Given this list of marker genes STIP1, KIF20A (NCBI Gene Id 94421), CDC20, NUDT1, RACGAP1, CCNE2, MELK (NCBI Gene Id 9833), H2AZ2, MKI67, MIS18A, XPOT, E2F8, NCAPG, CDKN3, CEP55, CMC2, TIMM10, DNAJC9, ESPL1, NEK2, PTTG3P, BIRC5, CCNB2, EZH2, CKS2, ASPM, PTTG1, PSMA7, TOMM70 (NCBI Gene Id 9868), SNRPG, QPRT, DLGAP5, GMPS, BLM, PFDN6, ORMDL2, TACC3, H2AZ1, NME1, SNRPC, HCCS, SLC52A2, MCM3, DSCC1, MCM2, FOXM1, KIF14, APOBEC3B, SNRPF, MRPS17, HMCES, COX7B (NCBI Gene Id 1349), TPX2, MCM6, CDK2, PIMREG, RNASEH2A (NCBI Gene Id 10535), JPT1, HMGB3, KPNA2, ZWINT, UBE2S, UBE2N, GTPBP4, STIL, MCM4, CENPE (NCBI Gene Id 1062), TXN, E2F1, KIF18B, TIMELESS, CDCA8, CENPI, CENPF, KIF11, PKMYT1, TXNRD1, CENPN, RAD54B, CDC45, KIF2C, SPAG5, TOP2A, FBXO5, RFC4, LAGE3, UBE2C, CENPA, CCNA2, NCAPG2, NCAPH, PDSS1, RAB5IF (RAB5 interacting factor), RRM2, TUBA1B, DONSON, NUSAP1, JMJD6, AURKA, CDC25A, TMPO, POLR2K, PSMD12, MCM10, PLK1, CDK1, TROAP, ECT2, NDC80, VRK1, BUB1, TRIP13, BYSL, NUTF2, GTSE1, GINS1, CENPU, CCNB1, MRPL12, CCT5, TUBA1C, PRC1, TTK, DDX39A, HMMR, CDCA3, MRPL15, RAD51, EXO1, TUBA1A, BOLA2, BUB1B, HJURP, KIF15, AURKB, FEN1, MYBL2, SHMT2, CHEK1, ITCH, MARS1 (NCBI Gene Id 4141), ELOC (elongin C), SLC7A5, H4C2, DSN1, KIF4A, OIP5, PARPBP, NUP93, MAD2L1, STMN1, POLQ, LMNB1, KIFC1, here is a description of the gene set: Up-regulated genes whose expression correlated with histologic grade of invasive breast cancer tumors: comparison of grade 1 vs grade 3. studied in species Homo sapiens Human Gene Set: SOTIRIOU_BREAST_CANCER_GRADE_1_VS_3_UP BACKGROUND: Histologic grade in breast cancer provides clinically important prognostic information. However, 30%-60% of tumors are classified as histologic grade 2. This grade is associated with an intermediate risk of recurrence and is thus not informative for clinical decision making. We examined whether histologic grade was associated with gene expression profiles of breast cancers and whether such profiles could be used to improve histologic grading. METHODS: We analyzed microarray data from 189 invasive breast carcinomas and from three published gene expression datasets from breast carcinomas. We identified differentially expressed genes in a training set of 64 estrogen receptor (ER)-positive tumor samples by comparing expression profiles between histologic grade 3 tumors and histologic grade 1 tumors and used the expression of these genes to define the gene expression grade index. Data from 597 independent tumors were used to evaluate the association between relapse-free survival and the gene expression grade index in a Kaplan-Meier analysis. All statistical tests were two-sided. RESULTS: We identified genes in our training set that were associated with histologic grade; most of these genes were involved in cell cycle regulation and proliferation. In validation datasets, the gene expression grade index was strongly associated with histologic grade 1 and 3 status; however, among histologic grade 2 tumors, the index spanned the values for histologic grade 1-3 tumors. Among patients with histologic grade 2 tumors, a high gene expression grade index was associated with a higher risk of recurrence than a low gene expression grade index (hazard ratio = 3.61, 95% confidence interval = 2.25 to 5.78; P <.001, log-rank test). CONCLUSIONS: Gene expression grade index appeared to reclassify patients with histologic grade 2 tumors into two groups with high versus low risks of recurrence. This approach may improve the accuracy of tumor grading and thus its prognostic value. from publication Sotiriou C, Wirapati P, Loi S, Harris A, Fox S, Smeds J, Nordgren H, Farmer P, Praz V, Haibe-Kains B, Desmedt C, Larsimont D, Cardoso F, Peterse H, Nuyten D, Buyse M, Van de Vijver MJ, Bergh J, Piccart M, Delorenzi M (PMID 16478745)